Given this list of marker genes TP53, here is a description of the gene set: studied in species Homo sapiens part of: Defective Intrinsic Pathway for Apoptosis Reactome Pathway: Loss of Function of TP53 in Cancer TP53 is the most frequently mutated tumor suppressor gene, with mutations present in more than 50% of human tumors and germline mutation in TP53 being underlying cause of the cancer-predisposing Li-Fraumeni syndrome. The TP53 gene maps to chromosomal band 17p13 and encodes a transcription factor that contains four functional domains. A transactivation domain (TAD) involves amino acid residues 1-61 and is involved in interaction with components of the transcription machinery. A DNA binding domain (DBD) involves amino acid residues 94-290 and interacts with specific DNA target sequences called p53 response elements. A C-terminal domain (CTD) involves residues 357-393 and regulates DNA binding. A tetramerization domain (TD) involves amino acids 325-355 and is needed for the formation of TP53 homotetramers. TP53 is considered the “guardian of the genome” as it is activated by DNA damage to initiate, depending on the amount of damage, cell cycle arrest, senescence or apoptosis. In addition, TP53 regulates the expression of DNA repair genes, and is involved in the regulation of metabolism and autophagy.<br>Most cancer-derived TP53 mutations are missense mutations that affect the central DNA binding domain of TP53 (amino acid residues 94-312). Eight hotspot amino acid substitutions in this region (R175H, G245S, R248Q, R248W, R249S, R273H, R273S and R282W) are found in close to 30% of TP53-mutated cancers. Based on their functional impact, TP53 mutations can be classified as 1) loss-of-function (LOF), 2) partial LOF (which may involve temperature sensitivity); 3) wild type-like (WT-L) or super-transactivating (ST) mutants; 4) mutants with altered specificity (AS), which are active or partially active on some but inactive on other TP53 target genes; 5) dominant-negative (DN) mutants, able to tetramerize with and inhibit the activity of the wild type TP53 protein. Some of the TP53 mutants, especially in the category of ST and AS mutants, are gain-of-function (GOF) mutants, able to interact with novel target genes and/or novel components of the transcriptional machinery.<br>Due to the complex function of WT-L, ST, AS and DN mutants of TP53, we have so far focused on annotating LOF mutants of TP53 which are unable to oligomerize due to mutations in the TD. Although accounting for a small percent of TP53 mutants, TD mutant are therefore considered to be completely defective in transcriptional activity, with no possibility of AS, DN and GOF effects. However, when overexpressed, some missense TD mutants of TP53 can form homotetramers and heterotetramers with the wild type TP53 which are partially functional and some extent of AS, DN and GOF effects may not be excluded for those mutants. In addition, the synthetic mutant p153(1-320) which consists of the first 320 amino acids and lacks the TD and CTD, while unable to tetramerize, can form stacked oligomers at the recombinant target gene promoter and induce transcription at a low level. Stacked oligomers are formed through interactions that involve amino acid residues outside the TD, which are facilitated by the presence of a target DNA sequence.